Given this list of marker genes Pard6g, Pard3 (NCBI Gene Id 93742), here is a description of the gene set: electronically inferred by orthology from the curated human pathway Reactome Pathway: Tight junction interactions This event has been computationally inferred from an event that has been demonstrated in another species.<p>The inference is based on the homology mapping from PANTHER. Briefly, reactions for which all involved PhysicalEntities (in input, output and catalyst) have a mapped orthologue/paralogue (for complexes at least 75% of components must have a mapping) are inferred to the other species. part of: Cell-cell junction organization species: Mus musculus